The following is a description of a gene set: Proteins with transporting functions can be roughly classified into 3 categories: ATP hydrolysis-coupled pumps, ion channels, and transporters. Pumps utilize the energy released by ATP hydrolysis to power the movement of substrates across the membrane against their electrochemical gradient. Channels in their open state can transfer substrates (ions or water) down their electrochemical gradient at an extremely high efficiency (up to 108 s-1). Transporters facilitate the movement of a specific substrate either against or with their concentration gradient at a lower speed (about 102 -104 s-1); as generally believed, conformational change of the transporter protein is involved in the transfer process. Diseases caused by defects in these transporter proteins are detailed in this section. Disorders associated with ABC transporters and SLC transporters are annotated here. Reactome Pathway: Disorders of transmembrane transporters studied in species Homo sapiens part of: Disease, and this is the list of marker genes: SLC6A3, SLC22A5, SLC39A4, NUP133, DERL3, NUP62, SLC9A6, SLC7A7, POM121, UBB, AVPR2, NUP85, PSMA1, SLCO1B3 (solute carrier organic anion transporter family member 1B3), PSMB4, PSMB2, NUP37, NUP58 (nucleoporin 58), ABCB4, SLC12A1, SEL1L, SLC5A2, SLC11A2, NUP107, SLC17A5, PSMC4, PSMB7, SLC40A1, SLC9A9, ABCG5, SLC24A1, LMBRD1, NUP88, OS9, SLC22A12, PSMD3, SLC36A2, UBC, SLC5A1, SLC1A3, NUP43, NUP214, SLC7A9, PSMB1, PSMA5, SLC24A5, PSMA2 (NCBI Gene Id 5683), SLC34A3, TPR, VCP, ABCC6, NUP188, SLC35A3, RAE1, NUP42, SLC4A4, SLC5A7, DERL2, PSMD11, SLC17A8, NUP205, PSMA6, SLC12A3, NUP54, RHAG, KCNJ11, CFTR, SLC24A4, SLC4A1, AVPR1A, SLC26A4, SLC12A6, SLC34A2, DERL1, PSMA4, PSMD12, BSG, SLC2A1, SLC35A1, SLC2A9, ERLIN2, CP, RNF185, POM121C, AVPR1B, NUP160, SLCO2A1, SLC2A10, PSMD6, ABCC9, ABCA12 (ATP binding cassette subfamily A member 12), SLC29A3, ABCB11, SEH1L, SLC6A19, PSMB3, SLCO1B1, NUP98, ERLIN1, ABCG8, SLC6A20, SLC35C1, PSMD13, ABCA1, SLC1A1, SLC67A1, ABCB6, RNF5, AVP, ABCA3, PSMD2, SEM1, SLC20A2, PSMC1, NUP153, SLC6A2, PSMC3, SLC3A2, RANBP2, SLC2A2 (NCBI Gene Id 6514), PSMA7, PSMD1, SLC27A4, PSMB5, SLC34A1, PSMD8, PSMD7, SLC33A1, PSMB6, AAAS, SLC26A3, PSMD14, GCK, SLC6A14, UBA52, NUP210, PSMC5, SLC3A1, ERLEC1, SLC16A1, NDC1, GCKR, NUP35, ADRM1, NUP93, ABCD4, APOA1, RPS27A, ABCC8, SLC26A2, ABCD1, SLC6A5, HEPH, NUP50, PSMC6, SEC13, SLC5A5, PSMA3, NUP155, HK1, ABCC2, PSMC2, SLC35A2 (NCBI Gene Id 7355, solute carrier family 35 member A2)